The following is a description of a gene set: Myositis studied in species Homo sapiens Human Gene Set: HP_MYOSITIS A general term for inflammation of the muscles without respect to the underlying cause., and this is the list of marker genes: SAT1, MEFV, IL12A-AS1, HNRNPA2B1, C4A, IL10, RNASEH2B, STAT4, FOXP3, LAMA2, PSMB9, MT-CO3, CAPN3, TNFRSF1A, KLRC4, ARPC5, IRF4, PTPN6, STING1, LSM11, IL12A, RNU7-1, RNASEH2C, LPIN1, IFIH1, PSMG2, IL23R, TREX1, FAS (NCBI Gene Id 355), IRAK1, SPP1, HLA-B, CCR1, TLR4, ADAR, UBAC2, SAMHD1, IFNGR1, RNASEH2A, MT-CO1 (mitochondrially encoded cytochrome c oxidase I), PSMB4 (proteasome 20S subunit beta 4), ERAP1, PSTPIP1, OBSCN